The following is a description of a gene set: studied in species Homo sapiens Human Gene Set: MODULE_375 GPCR signaling pathways (immune and neuro)., and this is the list of marker genes: CCR2 (NCBI Gene Id 90262), LPAR6, CCR1, CCR8, ADCYAP1R1, GABRA2, ADRA2A, RGR, FPR2, ACKR1, DEFB1, PTAFR, OR2F1, GRIK1, BDKRB2, C3AR1, GAP43, AVPR1A, CCR5, CXCL1, OPRK1, GRM3, AKAP12, TACR3, CXCR6, ADRB2, ADORA1, DGKA, HCRTR2, CXCL2, NPY1R (neuropeptide Y receptor Y1), RGS16, NPY, CXCL9, PTGER2, P2RY10, S1PR4, GRP, NMU, EDNRB, DGKI, GABRG2, FZD9, GNA14, GHRHR, DEFB4A, GRM2, TSHB, CXCL8, CX3CR1, GRM8, RGS5, RGS4, CCL23, ADRA2B, C5AR1, CXCR5, GPR183, GALR3, PLCB2, CCL3, CXCL13, GNA13, HCRTR1, NTSR1, DRD3, GCG, P2RY14, SCG5, UCN, GNA15, EDNRA, PDYN, GPR39, LANCL1, FZD2, PRB4, HCAR3, GNAL, GPR65, GIT2, FPR1, GPR182, ADGRE1, ADGRL1, RIN1, GRIN1, PTGFR, CCL17, CXCR4